Given this list of marker genes EEIG2, ANGPTL4, AJUBA, EREG, PPM1D, HGF, SFRP2, SLPI, GPM6B, SERTAD1 (NCBI Gene Id 29950), MAGED2, COL1A1, SEPTIN12, C3, CCNE1, SPARC, DIRAS2, GLRX, POU3F1, CAV2, AOC3, SFRP1 (secreted frizzled related protein 1), MRPL54, CALCRL (NCBI Gene Id 10203), CRLF1, MEGF10, ITGB7, ECRG4, PRDX4, CCL15 (C-C motif chemokine ligand 15), SLC1A3, TPPP3, TGFBI, MME, ACHE, DAXX, GNA12, PGM5, IL1RN, VCAN, SND1, ENDOD1, PLK4, RET, EMC2 (ER membrane protein complex subunit 2), EMB, KDM8, EVL, NREP, SDC1, C2orf68, DRAM1, TYK2, BAMBI, TUBA1A, BRPF1, CDC37, LRRC17, GAS6, PTX3, PTN (pleiotrophin), WNT5B, CLU (clusterin), here is a description of the gene set: studied in species Mus musculus from publication Ingram WJ, McCue KI, Tran TH, Hallahan AR, Wainwright BJ (PMID 17873912) Aberrant regulation of signalling mechanisms that normally orchestrate embryonic development, such as the Hedgehog, Wnt and Notch pathways, is a common feature of tumorigenesis. In order to better understand the neoplastic events mediated by Hedgehog signalling, we identified over genes regulated by Sonic Hedgehog in multipotent mesodermal cells. Widespread crosstalk with other developmental signalling pathways is evident, suggesting a complex network of interactions that challenges the often over-simplistic representation of these pathways as simple linear entities. Hes1, a principal effector of the Notch pathway, was found to be a target of Sonic Hedgehog in both C3H/10T1/2 mesodermal and MNS70 neural cells. Desert Hedgehog also elicited a strong Hes1 response. While Smoothened function was found necessary for upregulation of Hes1 in response to Sonic Hedgehog, the mechanism does not require gamma-secretase-mediated cleavage of Notch receptors, and appears to involve transcription factors other than RBP-Jkappa. Thus, we have defined a novel mechanism for Hes1 regulation in stem-like cells that is independent of canonical Notch signalling. Genes down-regulated in 10T1/2 cells (multipotent mesoderma) by expression of SHH. Human Gene Set: INGRAM_SHH_TARGETS_DN